Given this list of marker genes Siglech (sialic acid binding Ig-like lectin H), Surf4, Cd163, Tfr2, Timd2, Stab1, Scarf2, Ackr2, Enpp1, Ackr3, Lsr, Folr1, Abca7, Dmbt1, Lrp2, Mia2, Itgam, Lrp8, Scarb1, Ackr4, Cubn, Lrp1b, Enpp2, Colec12, Lrp6, Stab2, Folr2, Tfrc, Cd320, Vtn, Scarf1, Stbd1, Megf11, Ldlr, Olr1, Asgr1, Vldlr, Ildr1, Abca1, Endou, Scara5, Scarb2, Insr, Ssc5d, Cxcl16, Megf6 (NCBI Gene Id 72101), Marco, Mrc1, Megf10, Sdc1, Prg4, Cd44, Cd36, Lyve1, Mia3, Tex261, Msr1, Hmmr, Amn1, Apobr, Atp5f1b, Lgals3bp, Dab2, Itgb2, Lrp10, Lrp1, Amn, here is a description of the gene set: species: Mus musculus Binding specifically to a substance (cargo) to deliver it to a transport vesicle. Cargo receptors span membranes (for instance the plasma membrane or the endoplasmic reticulum membrane), binding simultaneously to cargo molecules and coat adaptors, to efficiently recruit the cargo molecules to nascent vesicles. Mouse Gene Set: GOMF_CARGO_RECEPTOR_ACTIVITY